The following is a description of a gene set: studied in species Homo sapiens Human Gene Set: TRAVAGLINI_LUNG_VASCULAR_SMOOTH_MUSCLE_CELL from publication Travaglini KJ, Nabhan AN, Penland L, Sinha R, Gillich A, Sit RV, Chang S, Conley SD, Mori Y, Seita J, Berry GJ, Shrager JB, Metzger RJ, Kuo CS, Neff N, Weissman IL, Quake SR, Krasnow MA (PMID 33208946), and this is the list of marker genes: MSRB3, MYL9, WFDC1, TPM2, SEMA5A (NCBI Gene Id 9037), ARHGDIB, RPS7 (NCBI Gene Id 6201), PTMA, CNN3, JAG1 (jagged canonical Notch ligand 1), MYL6, FRZB, ESAM, EPAS1, ACTA2, EGFL6, ITGA1, SOD3, RCAN2, EPS8, COX4I2 (NCBI Gene Id 84701), MYH9, NOTCH3, LRRC32, TPM4, HEYL, CALD1, EFHD1, ACTG2, PPP1R14A, SYTL2, TAGLN, CRIM1, RGS5, ECRG4, EZR, HES4, ADGRF5, KRT18, PARM1, TPM1, LMOD1, FHL5, CDH6, TM4SF1, INPP4B (NCBI Gene Id 8821), PDLIM7, MYLK, ISYNA1, TINAGL1, ACTN1, CAV1, LPP, SEPTIN7, HSPA2, CNN1, MCAM, BGN, PDGFA, IGFBP7, LGI4